The following is a description of a gene set: PURPOSE: To characterize the gene expression profiles of endometrioid endometrial cancers associated with lymph node metastasis in an effort to identify genes associated with metastatic spread. EXPERIMENTAL DESIGN: Tumors from 41 patients with endometrioid endometrial cancer grossly confined to the uterine cavity were evaluated. Positive lymph nodes were noted in 12 of 41 patients. RNA was analyzed for gene expression using the Affymetrix HG133A and HG133B GeneChip set, representing 45,000 array features covering >28,000 UniGene clusters. Data analysis was done using multidimensional scaling, binary comparison, and hierarchical clustering. Gene expression for several differentially expressed genes was examined using quantitative PCR. RESULTS: Gene expression data was obtained from genes that were detected in at least 5% of the cases. Supervised analysis of node-positive versus node-negative cases indicated that genes were significantly differentially expressed between the two classes at P < 0.005, 81 of which were differentially expressed by at least 2-fold at P < 0.005. Overexpressed genes included two cell cycle checkpoint genes, CDC2 and MAD2L1, which have previously been described in association with lymph node metastasis in other cancer types. The ZIC2 zinc finger gene was overexpressed in endometrial cancers with positive nodes versus those with negative nodes. CONCLUSION: Gene expression profiling of the primary tumors in patients with endometrioid endometrial cancers seems promising for identifying genes associated with lymph node metastasis. Future studies should address whether the status of nodal metastasis can be determined from the expression profiles of preoperative tissue specimens. species: Homo sapiens Human Gene Set: BIDUS_METASTASIS_UP from publication Bidus MA, Risinger JI, Chandramouli GV, Dainty LA, Litzi TJ, Berchuck A, Barrett JC, Maxwell GL (PMID 16397028) Genes up-regulated in endometroid endometrial tumors from patients with lymph node metastases compared to those without the metastases., and this is the list of marker genes: HNRNPA3P1, NF1, PLOD2, NSD2, TFRC, DBF4, MAPK1, KNSTRN, BPTF, GMNN, KIF11, FNDC5, MNS1, RAE1, LCA5L, ASF1B (anti-silencing function 1B histone chaperone), CCNA2, PHF10, NDRG3, RACGAP1, HSF2, AMD1, CCDC15, SGMS2, RLIM, UBXN2B, LARP4, DEPDC1, FEM1A, EIF4E, HULC, SRSF2, TYMS, PRKDC, EFHC1, ADNP, C5orf22, TMEM33, DCTN4, BCL7A, TPX2, PREPL, CCDC47, IFT74, MARCKS, OR4F3, TLK2, CCNB1, KDM6A, GET1, SFPQ, KCTD6, PCBP1 (NCBI Gene Id 5093), PPP2CA, CEBPG, CDK2AP1, PBK, WDHD1, VBP1, GID8, ZNF318, HNRNPR, RAB22A, ERCC6L, DNAAF2, HMGXB4, AGAP1, USP13, TSR1, CKAP5, COPS8, CCNY, RRM1, NAP1L1, STK24, ODC1, RCOR1, RAB28, SRSF12, DDX21, NCAPH, DSP, KLHL23, SNRPD1, AURKA, ARPP19, HNRNPD, CAND1, TRA2B, BUB1, CHEK1, DHFR, KLC1, MCM10, ANKRD54, RNF138, BIRC5, SRSF9, MEAF6, YWHAE, KIF4A, CDK1, MPHOSPH9 (M-phase phosphoprotein 9), CRY1, NPM1P22, NFIB, PLD6, EIF1, CENPA, AZI2, TRAV6 (T cell receptor alpha variable 6), TSR2, NRAS, CSE1L, RAB7A, VDAC1, TARDBP, MTDH, CDC6, TTF2, PSMD10, RFC5, CBLL1, GAS2L3, WBP11, PPP1R14C, HNRNPH3, PNMA8A, UBE2C, ARX, RABGGTB, RBBP4, CEP57, MAPKAPK5, SEC23A, ECT2, DLGAP5, RABGAP1L, ZNF568, MRPL42, SQLE, DKC1, HNRNPDL, HNRNPU, SLC66A1LP, RFC4, PTP4A1, FANCI, RMND5A, AZIN1, RRM2, CRKL, IFT81, YTHDF1, ZIC2, FSD1L, STRN3, CDC23, CENPN, CCNB2, CBFB, ATP6V0A2, NUP153, SMC1A, UBQLN2, MED14 (NCBI Gene Id 9282), KIF1B, PRELID3B, MAD2L1, RRN3, CREB5, HUWE1, G3BP1, MXD1, RHBDL3 (rhomboid like 3), SMS, H2AZ1, SEC24B, CDYL, HSP90AA1, UNK, NUSAP1, NCBP2, MLLT10, PLK4, SUMO4, ELAVL1, TFDP1, YBX1, NONO, EIF4A3, PATL1, KHDRBS1 (KH RNA binding domain containing, signal transduction associated 1), PAIP1, CCDC57, HNRNPK, MACROH2A1, SMC4, WAC, USP9X, HBS1L (NCBI Gene Id 22991), CENPF, KNL1, FEN1, SRD5A1, P4HA1 (prolyl 4-hydroxylase subunit alpha 1), TUBGCP4, PNMA1, PCNX1, PTGES3, NEMP1, PAK2 (p21 (RAC1) activated kinase 2), LMNB1, HMGB3, PAGE2, ATF2, HNRNPA2B1, SLC35B4, ZNF550, SSRP1, SRSF1